The following is a description of a gene set: Binding to large ribosomal subunit RNA (LSU rRNA), a constituent of the large ribosomal subunit. In S. cerevisiae, this is the 25S rRNA. species: Homo sapiens Human Gene Set: GOMF_LARGE_RIBOSOMAL_SUBUNIT_RRNA_BINDING, and this is the list of marker genes: RPL23, RPLP0P6, RPUSD4, RPL12, RPLP0, MRPL11